Given this list of marker genes Lrrk2, Taar1, Cav2, Gnas, Prmt5, Vps35, Palm, Drd2, Drd3, Oprm1, Drd4, Rgs8, Nherf1, Alk, Gnal, Gm527, Drd5, Gna11, Gnao1, Dtnbp1, Gna15, Drd1, Adcy5, Slc1a1, Adcy6, Gnb5, Ptger1 (NCBI Gene Id 19216), Htt, Gnai3, Ncstn, Gnaq, Oprd1, Klf16, Gna14, Flna (filamin, alpha), Rgs9, Rgs4, here is a description of the gene set: Mouse Gene Set: GOBP_G_PROTEIN_COUPLED_DOPAMINE_RECEPTOR_SIGNALING_PATHWAY species: Mus musculus A G protein-coupled receptor signaling pathway initiated by a dopamine binding to its receptor on the surface of a target cell, and ending with the regulation of a downstream cellular process.